Given this list of marker genes Ccl19-ps3, Ccl19-ps1, Ccl8, Ccl19-ps5, Ccl27a, Ccl20, Apol11a, Defa23, Pla2g2a, AY761185, Trem1, Ppbp, Ccl25 (NCBI Gene Id 320542), Lgals3, Arg1, Defa25, H2bc21, Nlrp6, Defa38, Lyz1, Defa30, Rpl30 (ribosomal protein L30), Ccl21d, Mbl1, Defa3, Defa29, Ccl19 (C-C motif chemokine ligand 19), Gbp7, Gzme, Trem3, Ninj1, Hrg, Cxcl12, Defa31, Gbp5, Defa26, Igtp, Lyzl6, Defa37 (NCBI Gene Id 100041895), Nts, Romo1, Hc, Defa5, Gzma, Defa42, Gm12250, Gzmd, Gbp2b, Defa24, Dao, Cst11, Pcyox1l, Defa21, Rps19, Defa2, Nos2, Cxcl11, Gapdh (glyceraldehyde-3-phosphate dehydrogenase), Syk (spleen tyrosine kinase), Gzmg, Gbp2, Cxcl1, Pomc, Mbl2, Ccl19-ps4, Ccl21b, Gzmc, Clec7a, Hamp2, Pglyrp3, Tac1 (tachykinin 1), Defa39, C8b, Defa17, Ltf, Spag11b, Defa41, Defb20, Lyz3, Pglyrp4, Bad, F2, Elane (elastase, neutrophil expressed), Defa34, Ccl21a, Defa35, Ccl11, Camp, Gapdhrt, Defa22, Kng1, Gapdhrt2, Lyz2, Gbp3, Gapdh-ps15, Ccl27al, Irgm2, Ncf1 (neutrophil cytosolic factor 1), C8g, Ccl28, Defb21, Pi4ka, Gzmf, Kng2, C8a, Defa40, Nppb, Fgl2, Bcl2l11, Ccl21f, Ifng, Cxcl10, Pglyrp1, Defa28, Myd88, Cxcl14 (NCBI Gene Id 80491), Tusc2, H2bc12, C9, Hmgn2, Ccl19-ps6, Ccl21e, Scnn1b, Ccl27b (C-C motif chemokine ligand 27b), Cxcl5, Ctsg, Defa20, Ccl22, Csnk2b, F2rl1, Nkg7, Usp7, Ccl1, Hamp, Gzmb, Cxcl9, Fcer2a, Prf1, Cxcl13, Hmgn2-ps, Ccl17, here is a description of the gene set: The disruption of an anatomical structure of another organism, leading to damage or temporary subversion of that structure. species: Mus musculus Mouse Gene Set: GOBP_DISRUPTION_OF_ANATOMICAL_STRUCTURE_IN_ANOTHER_ORGANISM